The following is a description of a gene set: Human Gene Set: GOBP_AMINO_ACID_ACTIVATION The modification of an amino acid to an active form, for incorporation into a peptide, protein or other macromolecule. studied in species Homo sapiens, and this is the list of marker genes: DARS2, FARSA, MARS2, QARS1, RARS2, DARS1, LRRC47, EPRS1, GATC, KARS1, TARS2, HARS2, VARS1, PARS2, NARS1, VARS2, EARS2, IARS1, SARS2, TARS3, AARS2, SARS1, CARS2, WARS2, GARS1, IARS2, TARS1, DALRD3, YARS2, QRSL1, RARS1 (NCBI Gene Id 84715), LARS1, FARS2, AARSD1, GATB, NARS2, AASDH, AARS1 (NCBI Gene Id 16), LARS2, CARS1, WARS1, HARS1, MARS1, FARSB, YARS1